The following is a description of a gene set: The progression of the glomerulus over time from its initial formation until its mature state. The glomerulus is a capillary tuft which forms a close network with the visceral epithelium (podocytes) and the mesangium to form the filtration barrier and is surrounded by Bowman's capsule in nephrons of the vertebrate kidney. The glomerulus is part of the nephron and is restricted to one body segment. studied in species Homo sapiens Human Gene Set: GOBP_GLOMERULUS_DEVELOPMENT, and this is the list of marker genes: AGTR2, PDGFRA, MIR125A, NOG (noggin), MAGI2, SULF1, VANGL2, ENPEP, ANGPT2 (angiopoietin 2), MPV17, MEF2C (myocyte enhancer factor 2C), CFLAR, CD34, PECAM1, LHX1, MYO1E, FOXJ1, NID1, HEYL, FOXC2, PPP3CA, LAMB2, NPHS1, HES1, BMP4, PROM1, EGR1, AQP1, EDNRB, PTPRO, PAX2, CD24, EDN1, KIRREL3 (NCBI Gene Id 84623), JAG1, EXT1, NOTCH2 (notch receptor 2), PDGFD, BASP1, CD2AP, IL6R, WWTR1, ITGB3, TEK, ADIPOQ, EDNRA, SERPINB7, IQGAP1, BCL2, NOTCH1, COMT, MTSS1, KLF15, TCF21, BMP7, OSR1, SULF2, PDGFB, LGR4, PODXL, NPHS2, GPR4, PDGFRB, PDGFA, RET, COL4A3, PLCE1, ASXL1, WT1, FOXC1, COL4A4, AMPD2, ANGPT1, ACTA2, NOTCH3